The following is a description of a gene set: Mucopolysaccharidosis IV A (MPS IVA, MPS4A, Morquio's syndrome, Morquio's; MIM:253000) is a rare, autosomal recessive mucopolysaccharide storage disease, first described simultaneously in 1929 by L Morquio (Morquio L, Sur une forme de distrophie familiale, Bull Soc Pediat, Paris, 27, 1929, 145-152) and JF Brailsford (Brailsford, JF, Chondro-osteo-dystrophy: roentgenographic and clinical features of child with dislocation of vertebrae, Am j Surg, 7, 1929, 404-410). MPSIVA is caused by a deficiency in N-acetylgalactosamine 6-sulfatase (GALNS; MIM:612222) which normally hydrolyses 6-sulfate groups of N-acetylgalactosamine 6-sulfate units of chondroitin sulfate (CS) and of galactose 6-sulfate units of keratan sulfate (KS). The result is accumulation of KS/DS in cells and overexcretion in urine. Severe osteochondrodysplasia is a commonly seen phenotype for this disease. The severity of the disease is variable but severe cases limits lifespan to their 20's or 30's. The gene coding for human GALNS was mapped to chromosome 16q24.3 and its structure described at the same time by two independent groups as comprising 14 exons and spanning approximately 40-50 kb (Nakashima et al.1994, Morris et al.1994). Reactome Pathway: MPS IV - Morquio syndrome A part of: Mucopolysaccharidoses species: Homo sapiens, and this is the list of marker genes: GALNS